Given this list of marker genes APOC2, MIR379, APOC1, LRPAP1, APOC3, here is a description of the gene set: species: Homo sapiens Any process that modulates the rate, frequency or extent of very-low-density lipoprotein particle clearance. Very-low-density lipoprotein particle clearance is the process in which a very-low-density lipoprotein particle is removed from the blood via receptor-mediated endocytosis and its constituent parts degraded. Human Gene Set: GOBP_REGULATION_OF_VERY_LOW_DENSITY_LIPOPROTEIN_PARTICLE_CLEARANCE